The following is a description of a gene set: Catalysis of an oxidation-reduction (redox) reaction in which hydrogen or electrons are transferred from each of two donors, and molecular oxygen is reduced or incorporated into a donor. studied in species Homo sapiens Human Gene Set: GOMF_OXIDOREDUCTASE_ACTIVITY_ACTING_ON_PAIRED_DONORS_WITH_INCORPORATION_OR_REDUCTION_OF_MOLECULAR_OXYGEN, and this is the list of marker genes: EGLN2, CYP4A11, TYRP1, CYP4V2, CYP21A2, CYP3A4, CYP2B6, CYP2S1, ALKBH8, CYP2A6, FADS6, CYP4X1, MICAL1, SCD, FTO, CYP11A1, MICAL3, KDM5A, AGMO, CYP27B1, PTGS1, P4HA2, NOS3, CYP2W1, CYP2A7, CYP11B1, TPH1, COQ6, CYP51A1, ALKBH5, TET2, HIF1AN, TBXAS1, DBH, CYP24A1, KDM1A, PHF8, MOXD1, AKR1C1, PTGS2, KDM2B, MICAL2, CYP4F22, ACTB, CYP46A1, CYP2D6, CYP1A2, CYP2C8, CYP3A7, FAXDC2, FA2H, CYP26A1, NLRP11, CYP19A1, ALKBH2, ESR1, CYP27C1, HSP90AB1, EGLN3, CYP39A1, PEDS1, FADS1, POR, JMJD4, NOS1, PHYH, KDM3B, FMO4, TET3, AKR1C2, FADS2, CYP2C9, KDM8, PCBD1, SQLE, AKR1C3, TMLHE, P4HA3, ALKBH4, COQ7, KDM3A, KMO, KDM4C, KDM5C, NOS2, ATP2B4, HR, PARK7, FADS3, HMOX2 (heme oxygenase 2), P4HB, CYP2E1, RSBN1, DOHH, CYP1B1, CYP3A43, CYP20A1, FMO5, CYP3A5, DEGS2, DEGS1, TH, RIOX2, CYP2C18, CYP4F12, AKR1D1, KDM4A (lysine demethylase 4A), CYP2J2, ALKBH1, SC5D, FADS2B, CYP4F3, P4HTM, KDM1B, FMO3, P4HA1, CYP11B2, CYP2A13, TET1, TPO, CYP27A1, TPH2, CYP17A1 (NCBI Gene Id 1586), P3H1, KDM6B, CAV1, CYP2C19, FMO2, PLOD3, CYP4F8, CYP4B1 (cytochrome P450 family 4 subfamily B member 1), PLOD1, BBOX1, JMJD6, CYP8B1, UTY, TYR, PHF2, PAM, KDM5B, CYP1A1, AKT1, CYP4A22, KDM2A, CALM3, TYW5, DYNLL1, PHYHD1, P3H3, RIOX1, OGFOD1, OGFOD3, KDM4D, CYP4Z2P, CYP2G1P, CYP26C1, PTGIS, EGLN1, OGFOD2, KDM4B, KDM5D, SCD5, HSP90AA1, ASPH, CMAHP, CYP4F11, CYP7B1, HSPBAP1, CYP4Z1, JMJD7, ALKBH3, P3H2, AKR1C4, PLOD2, CYP4F2, NOS1AP, CYP2F1, CYP2U1, CTHRC1, MOXD2P, CYP2R1, FMO1, CYP26B1, PAH, MSMO1, HMOX1, KDM7A, KDM4E, CH25H, KDM6A, CYP7A1